The following is a description of a gene set: Human Gene Set: MIR3116 studied in species Homo sapiens from publication Chen Y, Wang X (PMID 31504780) Genes predicted to be targets of miRBase v22 microRNA hsa-miR-3116 in miRDB v6.0 with MirTarget v4 prediction scores > 80 (high confidence targets)., and this is the list of marker genes: RASL12, KCNIP2, LACC1, ARRB1, CDK6, RAB7B (RAB7B, member RAS oncogene family), KCTD5, ZNF134, DNM3, OTX2, SESN2, WNT4 (NCBI Gene Id 54361), CBL, CCDC73, MAP7, DIP2B, PRAMEF14, PEX2, MICALL1 (NCBI Gene Id 85377), EMX1 (NCBI Gene Id 2016), ELAVL1, FHIP2B, KANSL1L, NYX, DOCK3, MECP2, SPATA22, NOL11, MLEC, TBKBP1, STPG4, AKIRIN1, DPM2, C6orf120, NWD1, PRAMEF1 (NCBI Gene Id 93189), ARSD, RNGTT, TTC28, ABCC1, KCTD12, SH3BP2, PRAMEF2, LSM14A, PHKG2, WT1, SOCS4, ATXN7L1, PRAMEF13, IQGAP3, GRAMD1B, KCNQ5, SPOUT1, PTPN20, FAM169A, RASSF2, ARHGAP31 (NCBI Gene Id 57514), FOXP1, PSMD10, ZNF382, SMIM24, NECAP1, FHL2, ADCY1, SCN2B, EFCAB14, FEZF2, SLC6A9, NIPBL, HHLA2, CA8, TMEM265, SEMA4G, DNAI2, ARID4A, RBPJL, CALR, STK26, OSTM1, SAP30L, CYB561D1, IL1RL1 (interleukin 1 receptor like 1), NCOA3, POLR1B, LDLRAD3 (low density lipoprotein receptor class A domain containing 3), ACSBG1, PPP3CB, MTURN, MEOX2, SHLD2, RAD50, ZDHHC22, CLTCL1, TSPAN11, RECQL5, MRPL43, AZI2, DDX53, SAA2, NRCAM, KCNE1, ERG28, UBE2V1, SOX13